Given this list of marker genes CDKN2A, GINS2, E2F1, CENPC, AURKB, ESCO1, HAUS2, CDC45, PKMYT1, MZT2B, H2AC18, PSMB4, CSNK2A1, NEK7, PSMD12, KIF23 (NCBI Gene Id 981), CEP43, HAUS1, DYNC1LI1, MAU2, GOLGA2, PPP2R2D, POLA2, CCNA2, PPP2R1A, FKBPL, AKAP9, GSK3B, KNL1, LIN9, PCM1, H2BC17, POLA1, RAE1, DYNC1H1, NINL, ORC2, NUP133, PMF1, CABLES1, MCM10, RPA3 (replication protein A3), FOXM1, EML4, CDC20, LPIN2, UBE2C, E2F2, MYC, CENPU (NCBI Gene Id 79682), VPS4A, NUP43, SET, MAPRE1, PSMD7, CENPA, GORASP1, TOP2A, CENPQ, PTK6, PPP2CB, HJURP, CDC16, PSMC1, CLASP1 (cytoplasmic linker associated protein 1), TUBB3, ERCC6L, CDC7, KIF2B, KIF2A, HDAC8, DYNLL2, KIF2C, SKA1, TUBB4B, E2F5, LIN54, SMC1A, MAD1L1, CDK11B, ARPP19, RFC2, ALMS1, NUP210, AAAS, H3C1, UBA52 (NCBI Gene Id 7311), PSMD11, NCAPD3, HAUS3, POLD4, RPA2, TP53, TUBGCP2, PRKAR2B, UBE2E1, TUBA1A, LPIN3, CENPI, CPAP, TUBB1, CENPH, PPP1R12B, BUB1B, RPS27A, GMNN, ORC4, NDC80, H3C15, AKT3, TICRR, DNA2, ANAPC4, NUP37, TUBG2, DYRK1A, BIRC5, H2BC3, NUP98, PPP2R5D, CDC25B (cell division cycle 25B), CDC27 (cell division cycle 27), CCND3, RPA1, CETN2, PRKACA, ANAPC16, TUBGCP4, PSMC6, SKP2, ESPL1, AKT1, CHMP4B, MNAT1, CTDNEP1, SMC4, SGO2, HSP90AA1, PPP2R2A, INCENP (inner centromere protein), PSMD6, CDCA8, ENSA, ORC3, CSNK1E, YWHAE, ANAPC2, ABL1, SEM1, TUBA1C, TAOK1, LYN, MCM5, CKAP5, MCM7, H2BC11, TUBB2B, CCNH, GTSE1, PRKCB, CENPS, RBBP4, CDC25C, HAUS7, H2AC6, AURKA, ANAPC11, NDE1 (nudE neurodevelopment protein 1), PSMC3, CDK4 (NCBI Gene Id 92978), PSMA2, CDK11A, H2AC14, EMD (NCBI Gene Id 2010), POLE, RAD21, TFDP1, TFDP2, KIF20A, OFD1, H4C1, MAD2L1, B9D2 (B9 domain containing 2), H2BC12L, SPAST, PPP2R1B, RRM2, YWHAG, BANF1, TUBB4A, SRC, DCTN1, POLE2, MCM8, MAX, TUBAL3, PPP1CC, HAUS5, DHFR, PPP2R5C, CNTRL, POLE3, PHLDA1, TUBB2A, MASTL, PSMC5, CLASP2, CDC25A, TUBG1, DYNLL1, GINS4, PPP2R3B, DYNC1LI2, DCTN2, CC2D1B, PSMD14, CDCA5, ORC1, FBXL18 (F-box and leucine rich repeat protein 18), CKS1B (CDC28 protein kinase regulatory subunit 1B), CHMP6, CCP110, NUP153, H2BC21, CEP290, CEP164, SMC3, FZR1, CENPF, PSMA7, TUBA4B, NUP205, PSMB1, UBE2I, CEP192, NUP88, CDK5RAP2, RAB8A, H2AC7, SPC24, TUBA3C, PSMD3, TUBA8, NCAPG, CNEP1R1, H2AX, NUP214 (NCBI Gene Id 9680), CEP72, KNTC1, H2BC14, MIS18BP1, HDAC1, TPR, CDC26, H2AC4, GORASP2, PSMA1, DCTN3, H2BC15, CHMP4A, RFC5, STAG1, CLIP1, CENPL, RCC2, PPP1R12A, RAN, CENPM, PRKCA, TUBGCP3, CHMP3, PSMA4, PPP2R5E, TUBA4A, ZWILCH, PHF8, LMNB1, HSP90AB1, NDEL1, NME7, SEH1L, PCNT, SPDL1, ACTR1A, EP300, CCND2, FEN1, ANAPC10, RAB1A, PPP2CA, NCAPD2, H2AB1, CHMP2A, HAUS6, FBXL7, LIN37, E2F6, PSMB6, ANAPC15, RBL1, H2BC13, HMMR, CEP131, DSN1, LPIN1, STAG2, FIRRM, NUP93, RBL2, FBXW11, SKP1, E2F4, OPTN, POLD3, CDKN1A, NUP58, CDC6, NUP42, GINS1, CDT1, PPP2R5A, CDK1, ITGB3BP, DYNC1I2, PSMC2, MCM4, TUBA3D, PPP2R5B, CSNK1D, POM121, RAB1B, MCM2, ZWINT, RBX1, CEP152, UBB, UBC, MIS12, MCPH1, CEP70 (NCBI Gene Id 80321), CHMP2B, H3-4 (H3.4 histone, cluster member), NDC1, VRK2, RFC4, PCNA, JAK2, CEP41 (NCBI Gene Id 95681), AKT2, VRK1, PSMB7, PPME1, NUP160, ANAPC1, TUBB6, NUP85 (nucleoporin 85), H2AC20, POLE4, HAUS8, NUF2, TUBGCP5, CENPK, CENPO, CHMP7, NCAPH, NCAPG2, NIPBL, BUB1, PSMA5, TMPO, RPS27, NUP188, SKA2, PDS5B, CCNE2, RANBP2, RANGAP1, NEDD1, CCNB2, CDK6, CCNB1, CDK7, CHMP4C, TUBA1B, RAB2A, UBE2S, PSMD1, PSMB2, CEP57, E2F3, TYMS, CSNK2B, RB1, LCMT1, ANAPC7, NCAPH2, CEP135, POLD2, ESCO2, NUP62, PPP1CB, CDKN2D, PAFAH1B1, USO1 (USO1 vesicle transport factor), TUBGCP6, POLD1, LEMD3, DBF4 (DBF4-CDC7 kinase regulatory subunit), CDKN2B, H3-3A, NUP155, CENPN, PSMD13, PSMD2, BUB3, RFC1, POM121C (POM121 transmembrane nucleoporin C), WAPL, PLK1, LEMD2 (LEM domain nuclear envelope protein 2), OBI1, TNPO1, SFI1, LMNA, KMT5A, UBE2D1, PSMA6, H2AZ2, MYBL2, PRIM2, ODF2, H2BC5, RFC3, PSMD8, AHCTF1, CENPT, TPX2, H2BC9, CDC23, CDKN1B, NEK2, DYNC1I1 (dynein cytoplasmic 1 intermediate chain 1), ORC6, SSNA1, NSL1, HAUS4, MCM6, CUL1, NEK6, ORC5, IST1, MAPK3, PSMB5, NUP54 (NCBI Gene Id 53371), CCND1, ANKLE2, CENPP, MZT2A, ANAPC5, NEK9, SDCCAG8 (SHH signaling and ciliogenesis regulator SDCCAG8), CENPE, NUP35, RPA4, WEE1, TK1, H2BC12 (H2B clustered histone 12), SPC25, BORA, SGO1, KPNB1, CDK2, LIN52, PTTG1, MZT1, SEC13, LBR, ZW10, H2BC26, PRIM1, MCM3, CDKN2C, MAPK1, CEP250, BLZF1, RCC1 (regulator of chromosome condensation 1), H2BC1, CEP78 (NCBI Gene Id 84131), TUBB, KIF18A, CDC14A, PSMB3, TUBB8B, H2AJ, NUDC, SMC2, PSMC4, ADRM1, NUMA1, BTRC, PLK4, CCNE1, CCNA1, SUMO1, XPO1, AJUBA, GINS3, H2BC4, CEP76 (NCBI Gene Id 79959), TUBB8, CEP63, LIG1, PSMA3, SIRT2, FBXO5, NUP50, TUBA3E, NUP107, CSNK2A2, CDKN1C, PDS5A, here is a description of the gene set: The events of replication of the genome and the subsequent segregation of chromosomes into daughter cells make up the cell cycle. DNA replication is carried out during a discrete temporal period known as the S (synthesis)-phase, and chromosome segregation occurs during a massive reorganization of cellular architecture at mitosis. Two gap-phases separate these cell cycle events: G1 between mitosis and S-phase, and G2 between S-phase and mitosis. Cells can exit the cell cycle for a period and enter a quiescent state known as G0, or terminally differentiate into cells that will not divide again, but undergo morphological development to carry out the wide variety of specialized functions of individual tissues.<p>A family of protein serine/threonine kinases known as the cyclin-dependent kinases (CDKs) controls progression through the cell cycle. As the name suggests, the kinase activity of the catalytic subunits is dependent on binding to cyclin partners, and control of cyclin abundance is one of several mechanisms by which CDK activity is regulated throughout the cell cycle. <p>A complex network of regulatory processes determines whether a quiescent cell (in G0 or early G1) will leave this state and initiate the processes to replicate its chromosomal DNA and divide. This regulation, during the <b>Mitotic G1-G1/S phases</b> of the cell cycle, centers on transcriptional regulation by the DREAM complex, with major roles for D and E type cyclin proteins.<p>Chromosomal DNA synthesis occurs in the <b>S phase</b>, or the synthesis phase, of the cell cycle. The cell duplicates its hereditary material, and two copies of each chromosome are formed. A key aspect of the <b>regulation of DNA</b> replication is the assembly and modification of a pre-replication complex assembled on ORC proteins.<p><b>Mitotic G2-G2/M phases</b> encompass the interval between the completion of DNA synthesis and the beginning of mitosis. During G2, the cytoplasmic content of the cell increases. At G2/M transition, duplicated centrosomes mature and separate and CDK1:cyclin B complexes become active, setting the stage for spindle assembly and chromosome condensation at the start of mitotic <b>M phase</b>. Mitosis, or M phase, results in the generation of two daughter cells each with a complete diploid set of chromosomes. Events of the <b>M/G1 transition</b>, progression out of mitosis and division of the cell into two daughters (cytokinesis) are regulated by the Anaphase Promoting Complex.<p>The Anaphase Promoting Complex or Cyclosome (APC/C) plays additional roles in <b>regulation of the mitotic cell cycle</b>, insuring the appropriate length of the G1 phase. The APC/C itself is regulated by phosphorylation and interactions with checkpoint proteins. part of: Cell Cycle Reactome Pathway: Cell Cycle, Mitotic studied in species Homo sapiens